Given this list of marker genes MOXD1, GATA6, AQP3, TM7SF2, NPIPA1, MAN1C1, SEMA6D, DNAJA4, ZFPM1, PPP2R2C, SUSD2, IL17RB, NIBAN1, ZFYVE1, CDKN1C, SLC4A11, COL1A1 (collagen type I alpha 1 chain), NOTCH3, CX3CL1, CASZ1, MYRFL, FZD1, RAB11FIP4, TNFRSF10C, CRYAB, GOLGA2P5, INSR, HR, ZNF439, NXF1, ZIC2, CSRNP1, FOXF1, CD101, CGAS, TRIM8, IHH, REEP1, TMEM63A, METRNL, ZNF600, FOXP4, NRARP, FGF18, STK40, SMAD9, DHRS3, GNA11, ASS1, IGF1R, PROC, TAF3, LMO2, MEGF6, SHC4, REG3A, KCNJ12, KSR1, FGF13, GPR37, KLHL21, KCNK3, PLIN4, APAF1, GABRE, RHOB, CYP11B2, NEFL, PGF, ACSL1, NUAK1, MAFB, APC2, GABBR2, NTN1, CLU, ANGPTL2, PPL, MICALL2, TEX15, WNT5B, RORA, ARIH1, GRHL3, ADAP2, MYLIP, FOXN3, MXD1, SYNJ2, ZNRF3, SIPA1L2, BCOR, IRX5, HUNK, OGA, KCNH2, DLG4, CDYL2, ELMOD1, UBE2QL1, VDR, BMP2, WNT7B, ULK1, RASGRP2, RGCC, EGR4, PPP1R16B, ABHD16A (abhydrolase domain containing 16A, phospholipase), H2BK1, ANKRD18A, SOX8, GMCL1, CELF3, HEY2, SASH1, ID4, DLC1, ADCY1, BIK, TENT5C, ZNF385A, CFB, RUBCNL, TNFRSF10D, EPHB3, ITSN2, LMNTD2-AS1, MAP7, KHDRBS3, FRY, MAPK14 (NCBI Gene Id 1432), PLPP3, CEMIP, MROH6, LIMS2, TNPO2, HSPA1B, MAP1LC3B, CXCL14, ULBP1, LBH, ZNF436, TSHZ3, SLC9A3, RBP7, ARX, AUTS2, CRYBA2, ELFN1, ST8SIA2, VSIR, CRAMP1, CYTH1, SOBP, PGAP1, AVIL, IL1RN, NGFR, LY6D, SLC16A14 (NCBI Gene Id 151473), MIR3939, LONRF3, UBE2Q2P1 (UBE2Q2 pseudogene 1), CGNL1, PLCD1, GKAP1, EPPK1, NDRG1, ST3GAL1, PYCARD-AS1, ARRB1, ABTB3, OXTR, SELENOP, HIC2, METAP2, SMAD7, LINGO1, DLX2, CACHD1 (cache domain containing 1), PLA2G4F, ATP2C2-AS1, DEDD2, DOK4, CXCR3, MKX, DPYSL4, RAB11FIP1, ADAMTS10, DOC2B, GALR2, IGF2, IGFBP3, CTDSP2, C7orf57, ELAVL3, RAB3IP, VASN, COL27A1, RTN4R, NPIPB3, TAF5, MX1, TCFL5, RUNX3, STOX2, THUMPD3-AS1, EDDM13, EFNA3, KDM7A, ARHGEF6, OTULINL, ARG2, FOXO3, ARHGAP26, HS6ST3, NPTX1, EPB41L3, CLIC3, RPP25, PTPRJ, ENSG00000255367, SERINC5, ACAP1, SEMA4D, GRK5, ZKSCAN2 (zinc finger with KRAB and SCAN domains 2), ULBP2, PBX2P1, KLK15, EPB41L4B, MXRA5, SLC35E1, EFHD1, ANKRD20A11P, RASGRP1, FAM43A (family with sequence similarity 43 member A), CLDN6, PPP1R13B, NPPC, IFIT3, ABCB9 (ATP binding cassette subfamily B member 9), TNFRSF25, RASSF5, MAF, ERFE, PCSK5, COL18A1, HSPH1, TLE1, EPHA4, RAB11FIP3, ZNF548, CKB, BCL2L11, TUFT1, SMIM32, CABP7, FRYL, WHRN, HBA1 (hemoglobin subunit alpha 1), DIO3 (NCBI Gene Id 1735), LUZP1, KISS1R, SYNE2, S100A3, RBM38, PAK6, HSD11B2, MARCHF3, EPB41 (NCBI Gene Id 2035), COL8A2, PRKCH, RCOR2, SLC6A2, ZNF750, PTX3, HSPA1A (heat shock protein family A (Hsp70) member 1A), HSPA6, HEY1, CELF2 (CUGBP Elav-like family member 2), OVOL1 (ovo like transcriptional repressor 1, NCBI Gene Id 5017), PALMD, LGALS2, KIT, ABHD6, STBD1, PLCXD2, ARFGEF3, TOX, CAPN3, ZCCHC24, SPATA13, NLRP1, PRSS33, GFPT2, EPB41L5, RET, FOLR2, GPATCH2L, LINC01666, KMT5C, HSPB1, AIPL1, CITED1, THEMIS2, STAR, CNNM4, JAG1, UNC5B, INHBB, NFATC1, RPL31P46, RCAN1, BLMH, CRISPLD2, TACC1 (transforming acidic coiled-coil containing protein 1), SLC39A8, SHANK3, CNKSR3, LAMP3, EVPL, DPF1, ARID1B, CHST2, TP53INP2, BAMBI, PCYT2, LRRC37A4P, GLIS2, ACVR1C, GPT2, RASEF, SLIT2, SOCS3, PDE4DIP (phosphodiesterase 4D interacting protein), HS6ST1, COL9A3, SHISAL1, ID2, DGAT2, ZSWIM6, CYGB, ATP11A, ARHGEF17, SMAD6, TSC22D3, EGR1, SLC35E4, CDC42EP4, GRTP1, WFDC5, SEPTIN5, FOXF2, PSD, TNRC6C, KLHL29, here is a description of the gene set: p53 and p63 belong to a family of sequence-specific transcription factors regulating key cellular processes. Differential composition of the p53 and p63 DNA-binding sites may contribute to distinct functions of these protein homologues. We used SELEX (systematic evolution of ligands by exponential enrichment) methodology to identify nucleic acid ligands for p63. We found that p63 bound preferentially to DNA fragments conforming to the 20 bp sequence 5'-RRRC(A/G)(A/T)GYYYRRRC(A/T)(C/T)GYYY-3'. Relative to the p53 consensus, the p63 consensus DNA-binding site (DBS) was more degenerate, particularly at positions 10 and 11, and was enriched for A/G at position 5 and C/T at position 16 of the consensus. The differences in DNA-binding site preferences between p63 and p53 influenced their ability to activate transcription from select response elements (REs) in cells. A computer algorithm, p63MH, was developed to find candidate p63-binding motifs on input sequences. We identified genes responsive to p63 regulation that contain functional p63 REs. Our results suggest that the sequence composition of REs could be one contributing factor to target gene discrimination between p63 and p53. Genes up-regulated in the HMEC cells (primary mammary epithelium) upon expression of the transcriptionally active isoform of TP63 off adenoviral vector. from publication Perez CA, Ott J, Mays DJ, Pietenpol JA (PMID 17563751) studied in species Homo sapiens Human Gene Set: PEREZ_TP63_TARGETS